Given this list of marker genes RABEP2, SLC16A7, IMMP2L, POLA1, IFT140, CXorf38, SLC2A3, DDR1, EVA1A, PNPO, EVL, TFAM, GUF1, UTP25, EIF3K, EPS15 (epidermal growth factor receptor pathway substrate 15), PIK3AP1, BEND5, MYCL, TPK1, CCDC88A, TRIM7, DNMT3A, CD40, DYSF, SERPINB2, ARHGEF37, AP1M1 (adaptor related protein complex 1 subunit mu 1), ABI2, CHAC2, MTMR6, HYCC1, FBXO33, MYO10, YPEL2, MID1IP1, SCOC, CSNK2A1, ZNF418, EXOSC1, LRP4, ANKRD50, ARHGAP19, CD28, INPP5F, TESC, C16orf54, POGK, AKAP11, ICE2, PLPP1, TBC1D9, PHB1, PADI4, DOLK, VCL, PTGIS, ZNF141, RCN1, C2CD5, SLC12A5, THUMPD3, RPS3, MEIS1 (NCBI Gene Id 4211), SMAD5, ZNF445, SEPTIN6, CASC3, RAI1, PHETA2, PYCR3, VAMP7, GNGT2, CYB561A3, CLIP1, ZNF229, LTF, HLTF, DIPK2A, SIKE1, PRG4, SLC43A3, HPGDS, PSIP1 (NCBI Gene Id 93428), FTX, KCTD6, HLA-G, AKT3, B4GALT5, PPP1R12B, EP300, DUSP22, MAPK8 (mitogen-activated protein kinase 8), PATJ, SGF29, UGT8, CD1D, MALT1, RPAP2, CD99L2, CTDSP2, MARCO, TRAF5, NSD1, VKORC1, ENSG00000267882, NR1H3, SMUG1, ACSL5, FCRLA, CD300LB, ANKMY2, ROGDI, GNA12, CLIC4, ABCA3, REPS2, ZC3H7B, ACO1, EVI2B, FUOM, CHD3 (chromodomain helicase DNA binding protein 3), C1orf53, ICAM2, ADAM22, TBCCD1, CTSW, CDK14, UBFD1, PRKACB, PLPBP, TMEM178A, H2BC13, SCAP, PURA, FAM117A, PGLYRP2, ST3GAL2, SLC22A23, ITPR1, GPHN, CD48, FOXJ3, RGS12, TCF7, CCDC93, ARMC1, INPP5B, CSE1L, TIFA, MECP2, KLRC1, LPAR6, ARHGAP30, COX4I1, BMP2, CD7, CNN2 (NCBI Gene Id 1265), RAPGEF1, RPL11, IL6ST, SLC4A7, PIKFYVE, ENTPD6, AHSP, S100PBP, TMEM208 (NCBI Gene Id 29100), KBTBD11, ENPP4, HPSE, FCN1, ARHGAP11A, LYSMD2, TOX4, SLC25A31, UBAC2, ASAP2, QPRT, PRDX3, TMCC3, UQCC3, ITM2C, SULF2, MTOR, SGK3, FKBP9, TNFRSF14, INPP4B (inositol polyphosphate-4-phosphatase type II B), GHITM, CTCF, CIITA, MSL1, IVD, ARPC5L, GANC, KBTBD8, ATMIN, MSL3, RAP1A, CEPT1 (choline/ethanolamine phosphotransferase 1), here is a description of the gene set: Genes up-regulated in monocytes in response to M. tuberculosis 19 kDa lipopeptide: 3h versus 24h. In innate immune responses, activation of Toll-like receptors (TLRs) triggers direct antimicrobial activity against intracellular bacteria, which in murine, but not human, monocytes and macrophages is mediated principally by nitric oxide. We report here that TLR activation of human macrophages up-regulated expression of the vitamin D receptor and the vitamin D-1-hydroxylase genes, leading to induction of the antimicrobial peptide cathelicidin and killing of intracellular Mycobacterium tuberculosis. We also observed that sera from African-American individuals, known to have increased susceptibility to tuberculosis, had low 25-hydroxyvitamin D and were inefficient in supporting cathelicidin messenger RNA induction. These data support a link between TLRs and vitamin D-mediated innate immunity and suggest that differences in ability of human populations to produce vitamin D may contribute to susceptibility to microbial infection. from publication Liu PT, Stenger S, Li H, Wenzel L, Tan BH, Krutzik SR, Ochoa MT, Schauber J, Wu K, Meinken C, Kamen DL, Wagner M, Bals R, Steinmeyer A, Zügel U, Gallo RL, Eisenberg D, Hewison M, Hollis BW, Adams JS, Bloom BR, Modlin RL (PMID 16497887) studied in species Homo sapiens Human Gene Set: GSE8921_3H_VS_24H_TLR1_2_STIM_MONOCYTE_UP